Given this list of marker genes Sec24b, Brd2, Rps7, Map3k7, Rara, Abl2, Lias, Kdm6a, Itpk1, Pax3, Kat5, Bcl10, Ptk7, Kat2a, Bmp7, Ttbk2, Wnt1, Ift172, Spint1, Ipmk, Ferd3l, Dchs1, Gli2, Twist1, Gpr161, Celsr1, Cplane2, Marcks, Abl1, Prickle1, Mks1, Nckap1, Rock2, St14, Tcf7l2, Foxa1, Plxnb2, Rgma, Trim71, Cecr2, Setd2, Smarca1, Lrp2, Rpgrip1l, Gorab, Zfp36l1, Pax6, Casp8, Tulp3, Tmed2, Bmi1, Hes5, Hif1a, Luzp1, Tfap2a, Cited2, Ssbp3, Stil, Grhl2, Sox17 (NCBI Gene Id 20671), Tsc2, Stk3, Ift140, Lhx2, Cfl1, Fuz, Rnf220 (ring finger protein 220), Hes3, Fzd6, Deaf1, Sall2, Dvl1, Ift57, Pkd2, Lmo4, Ptch1, Plod3, Pax2, Wdr83, Tctn1, Inka1, Arhgap35, Mthfd1l, Spint2 (serine protease inhibitor, Kunitz type 2), Ovol2, Dvl2, Mib1, Tsc1, Pfn1, Cby1, Zic2, Pkd1, Lrp6, Gbx2, T, Sall4, Phactr4, Bmp4, Bmp5, Sdc4, Enah, Pax7, Gatad2a, Gsc, Sema4c, Vangl2, Aldh1a2, Rala, Ski, C2cd3 (C2 calcium-dependent domain containing 3), Hes1, Alx1, Foxb1, Mthfd1, Folr1, Slc39a12, Epha2, Brpf1, Fkbp8, Fgf8, Kif20b, Phgdh, Nf1 (NCBI Gene Id 320618), Tbc1d32, Sfrp1, Arl13b, Cobl, Kif3a, Shh, Wdpcp, Kdm2a, Dzip1l, Specc1l, Apaf1, En1, Ift52, Zic5, Glmn, Traf3ip1, Tgfb1, Cc2d2a, Plxna2, Mnx1, Tgif1, Sema3c, Rab23, Prkaca, Vasp, Scrib, Nup133, Grhl3, Sufu, Sall1, Med12, Akp3, Ift122, Tgfb2, Casp3, Coq7, Cthrc1, Traf6, Nodal, Prkacb, Notch1, Opa1, Foxa2, Nup50, Wdr19, Gas1, Mthfr, Psen2, Tead2, Ambra1, Intu, Smo, Dlc1, Gli3, Rarg, Fzd3, Cdk20, Nog, Adm, Hectd1, Bbs4, Cluap1, Tmem107, Kdm2b, Tcf7, Shroom3, Sfrp2, Zeb2, Wnt3a, Gdf7, Arid1a, Psen1, Atp6ap2, Stk4, Wnt5a, Dact1, here is a description of the gene set: studied in species Mus musculus Mouse Gene Set: GOBP_NEURAL_TUBE_DEVELOPMENT The process whose specific outcome is the progression of the neural tube over time, from its formation to the mature structure. The mature structure of the neural tube exists when the tube has been segmented into the forebrain, midbrain, hindbrain and spinal cord regions. In addition neural crest has budded away from the epithelium.